Given this list of marker genes Ephb1, Pax2, Hoxd3, Egr2, Atp8b1, Sema3f, Nrp2, Ephb2, Plxna3, Neurog1, Hoxb1, Plxna1, Hoxa1, Hoxb3, Dmd, Mafb, Nrp1, Gli3, Tifab, Plxna4, Tfap2a, Hoxa3, Kcna2 (NCBI Gene Id 16490), Sema3a, Phox2a, Tbx1, Hoxb2, Chrnb2, Adarb1, Six1, Cited2, here is a description of the gene set: studied in species Mus musculus The process in which the anatomical structure of the cranial nerves are generated and organized. The cranial nerves are composed of twelve pairs of nerves that emanate from the nervous tissue of the hindbrain. These nerves are sensory, motor, or mixed in nature, and provide the motor and general sensory innervation of the head, neck and viscera. They mediate vision, hearing, olfaction and taste and carry the parasympathetic innervation of the autonomic ganglia that control visceral functions. Mouse Gene Set: GOBP_CRANIAL_NERVE_MORPHOGENESIS